Given this list of marker genes EIF4G1, ATG9B, SMARCA1, CCND1, CHPF, ADAMTSL1, HS6ST2, LRCH4, OTP, CCDC106, IP6K1, ANKZF1, BSN, PPFIA3, CCND2, ZNF423, DNAAF3, AP3D1, ING4, USP2, EMC6, ACHE, VEZF1, FANCA, here is a description of the gene set: Genes having at least one occurence of the motif CGCTGCT in their 3' untranslated region. The motif represents putative target (that is, seed match) of human mature miRNA hsa-miR-503 (v7.1 miRBase). Human Gene Set: CGCTGCT_MIR503 studied in species Homo sapiens